Given this list of marker genes Frem2, Rab10, Prl8a8, Pcmtd2, Dipk2a, Arhgap36, Qpct, Apob, Slain2, Gsr, Ccr4, Kcnn1, Serbp1, Dhfr, Eif1ad4, Phactr2, Slc23a2, Ehbp1, Dkk1, Siah1a, Ednrb, Agbl2, Atrx, Tpsg1, Eif1ad8, Sort1, Zfp709, Thbs2, Otx2, Igf1, Btbd8, Eif1ad2, Txndc16, Bdp1, Mindy2, Abhd3, Fbn1, Ttc9c, Tmem52b, Grik2, Btg3, Hnrnpf, Kmt2c, Smim15, Abcg1, Chd9, Steap2, Pak3, Mylk4, Mis12, Thap1, Peg10, Gabrb3, Fam169a, Abcb7, Zup1, Amot, Fbxo33, Klrb1f (NCBI Gene Id 338509, killer cell lectin-like receptor subfamily B member 1F), here is a description of the gene set: from publication Chen Y, Wang X (PMID 31504780) Mouse Gene Set: MIR_7062_3P studied in species Mus musculus Genes predicted to be targets of miRBase v22 microRNA mmu_miR_7062_3p in miRDB v6.0 with MirTarget v4 prediction scores > 80 (high confidence targets).